Given this list of marker genes ALOXE3, RAF1, MBTPS2, EDARADD, ZEB2, PERP (p53 apoptosis effector related to PMP22), COQ2, RYR1, LMNB1, PKP1 (NCBI Gene Id 5317), ALOX12B, ALK, FUCA1, NTRK1, ERCC6, BCS1L, SOX5, EDA, RETREG1, KIF1A, NGF, KRT14, PAX9, EDAR, CLDN10, ALPK1, SPTLC2, WNK1, TRPV3, ERCC8, NRAS, NGLY1, SCN9A, BRAF, NFKBIA (NFKB inhibitor alpha), CAMK2B, TP63, DPP9, here is a description of the gene set: species: Homo sapiens Anhidrosis Human Gene Set: HP_ANHIDROSIS Inability to sweat.